Given this list of marker genes ANAPC15, UBE2C, ANAPC16, RB1, CDC27, ANAPC11, ANAPC10, UBE2E1, UBE2S, CDC26, ANAPC7, SKP2, ANAPC4, CDC23, ANAPC2, CDC16, UBE2D1, ANAPC1, FZR1, ANAPC5, here is a description of the gene set: Aberrant regulation of mitotic exit in cancer due to RB1 defects species: Homo sapiens Human Gene Set: REACTOME_ABERRANT_REGULATION_OF_MITOTIC_EXIT_IN_CANCER_DUE_TO_RB1_DEFECTS